Given this list of marker genes NAMPT, SMPDL3A, CCL15, TNFSF9, SPRR1A, LYL1, IFIH1, TRIM5, CXCL10, ALDOC, UBE2A, UBA7, BCL2A1, LGMN, GGPS1, SAP30, NCF2, CPXM1, NPY, NSUN4 (NOP2/Sun RNA methyltransferase 4), FNDC3A, NCKAP1L, PFKL, MMP10, EIF2S3, PTPRC, HCLS1, C1QB, GLRX, PYHIN1, EGLN1, LAT2, XDH, SERPING1, CCL4, RBBP9, TOR1AIP2, IFT20, CTSH, CH25H, DAXX, IFITM3, NDRG2, CFP, GATM, ANXA4, UBE2L6, MT1X, SPHK1, TYROBP, NCF4, B3GNT2, NUPR1, IRF7, SP100, RTF2, SH3BGRL2, IFIT2, FAM162A, CSNK1D, ATP6V1B2, C3AR1 (complement C3a receptor 1), CTSB, SOCS3, PRDX5, IFIT3, MBD1, H2BC4, ERO1A, CACUL1, MMP3, DNAJC5, ADAM8, MKRN1, RETREG1, PRRX1, VAV1, NDRG1, IRGM, SELPLG, LDLR, CXCL2, PLAC8, FKBP7, CCL5, ZNFX1, MT1F, KRT7, CCL7, SKAP2, RAB3D, PDK1, GCNT2, PLEKHO1, SERPINB9, MPEG1, MXI1, ALDH1A2, CD300C, IRF9, IFI27L2, LST1, CXCL14, HP, IQGAP1, OGN, CASP4, SAT1, USP18, GADD45A, STAB1, NCF1, FPR1, HIPK3, ACSL4, SPECC1, ABCA1, ITGB2, BID, TAP1, TAPBP, EDEM2, DDIT3, TGOLN2, GABPA, FCGR2B, CSF2RA, CPXM2, APOBEC1, AGRN, TGFBI, PNPT1, GZMH, IGFBP3, IL7R, CHCHD10, MSRB1, PSMB10, GMFG, ACP2, MCOLN2, APOD, PLA2G7, ITGAM (NCBI Gene Id 3684), ABCG1 (ATP binding cassette subfamily G member 1), FERMT3, CD72, CTSE, LMO2, SLFN12, LYZ, CCR1, LCP1, EVI2A, GRN, GBP2, CLEC4D, H2AC18, PSME2, PSMB8, BNIP3L, STOM, FCGR1A, GRINA, PNP, GBP4, CTSZ, SEMA7A, TMEM45A, HES6, ADGRE1, HLA-B, ADAR, AK4, IGFBP5, NPR3, PLIN2, MID1IP1, C5AR1 (complement C5a receptor 1), ACOD1, CMPK2, ISG20, TBC1D22A, BHLHE40, RNF34, ARNT, ISG15, CCL3 (C-C motif chemokine ligand 3), STAT1, SRGN, PFKP, IL18BP, HCK, IFIT1B, NT5E, H1-2, RAB8B, TOR3A, PSMB9, SOD2, DDX3Y, CYP4V2, NR1H2, UCK2, MEOX2, CCL23, RAC2, CD52, DHRS7, APP, PTPN6, C2, ITGAX, NAPSA, CRABP2, TMEM229B, AP3S1, C1QC, PCSK5, PROCR, LILRB1, PCYT1A, SGPL1, GPC4, SGCB, LGALS3BP, IFI35 (interferon induced protein 35), CCL8, GBA1, CSF1R, here is a description of the gene set: Human Gene Set: MARKEY_RB1_ACUTE_LOF_DN studied in species Mus musculus from publication Markey MP, Bergseid J, Bosco EE, Stengel K, Xu H, Mayhew CN, Schwemberger SJ, Braden WA, Jiang Y, Babcock GF, Jegga AG, Aronow BJ, Reed MF, Wang JY, Knudsen ES (PMID 17452985) Genes down-regulated in adult fibroblasts with inactivated RB1 by Cre-lox: acute loss of function (LOF) of RB1. Functional inactivation of the retinoblastoma tumor suppressor gene product (RB) is a common event in human cancers. Classically, RB functions to constrain cellular proliferation, and loss of RB is proposed to facilitate the hyperplastic proliferation associated with tumorigenesis. To understand the repertoire of regulatory processes governed by RB, two models of RB loss were utilized to perform microarray analysis. In murine embryonic fibroblasts harboring germline loss of RB, there was a striking deregulation of gene expression, wherein distinct biological pathways were altered. Specifically, genes involved in cell cycle control and classically associated with E2F-dependent gene regulation were upregulated via RB loss. In contrast, a program of gene expression associated with immune function and response to pathogens was significantly downregulated with the loss of RB. To determine the specific influence of RB loss during a defined period and without the possibility of developmental compensation as occurs in embryonic fibroblasts, a second system was employed wherein Rb was acutely knocked out in adult fibroblasts. This model confirmed the distinct regulation of cell cycle and immune modulatory genes through RB loss. Analyses of cis-elements supported the hypothesis that the majority of those genes upregulated with RB loss are regulated via the E2F family of transcription factors. In contrast, those genes whose expression was reduced with the loss of RB harbored different promoter elements. Consistent with these analyses, we found that disruption of E2F-binding function of RB was associated with the upregulation of gene expression. In contrast, cells harboring an RB mutant protein (RB-750F) that retains E2F-binding activity, but is specifically deficient in the association with LXCXE-containing proteins, failed to upregulate these same target genes. However, downregulation of genes involved in immune function was readily observed with disruption of the LXCXE-binding function of RB. Thus, these studies demonstrate that RB plays a significant role in both the positive and negative regulations of transcriptional programs and indicate that loss of RB has distinct biological effects related to both cell cycle control and immune function.